The following is a description of a gene set: species: Homo sapiens The smaller of the two subunits of a ribosome. Human Gene Set: GOCC_SMALL_RIBOSOMAL_SUBUNIT, and this is the list of marker genes: RPS7, RPS14, RPS8, RPS3A, RPS4Y2, RPS17, RPS23, MRPS28, RPS25, MRPS7, RPS27A, MRPS17, RPS5, MRPS10, RPS19, RPS2, RPS4Y1, RPS27 (NCBI Gene Id 6232), RACK1, RPS15, RPS10, MRPS5, RPS3, RPS15A, MRPS23, MRPS33 (mitochondrial ribosomal protein S33), RPS27L, RPS9, MRPL42, EIF2A, LARP4, MRPS14, MRPS15, MRPS18B, RPS29, RPS24, MRPS25, RPS16 (ribosomal protein S16), MRPS2, MRPS35, RPSA2, MRPS9, MRPS34, MRPS31, DDX3X, RPSA, MRPS22, NPM1, CHCHD1 (NCBI Gene Id 118487), MRPS21, RPS21, RPS11, DAP3, RPS12, MRPS6, AURKAIP1, RPS18, MRPS26, RPS10P5, MRPS27, MRPS18A, PTCD3, RPS20, FAU, MRPS11, RPS4X, MRPS18C (NCBI Gene Id 51023), RPS6, DHX29, RPS13, RPS28, MRPS12, MRPS24, MRPS16, RPS26